The following is a description of a gene set: Genes up-regulated in CD8 T cells: naïve versus effectors. During acute viral infections, naïve CD8+ T cells differentiate into effector CD8+ T cells and, after viral control, into memory CD8+ T cells. Memory CD8+ T cells are highly functional, proliferate rapidly upon reinfection and persist long-term without antigen. In contrast, during chronic infections, CD8+ T cells become “exhausted” and have poor effector function, express multiple inhibitory receptors, possess low proliferative capacity, and cannot persist without antigen. To compare the development of functional memory T cells with poorly functional exhausted T cells, we generated longitudinal transcriptional profiles for each. studied in species Homo sapiens Human Gene Set: GSE41867_NAIVE_VS_EFFECTOR_CD8_TCELL_UP from publication Doering TA, Crawford A, Angelosanto JM, Paley MA, Ziegler CG, Wherry EJ (PMID 23159438), and this is the list of marker genes: MEN1, HTATIP2, LMAN2, NUBPL, SMARCB1, ANP32E, SSB, SEH1L, ATP11A, GNB1L, ELL2, ETV5, NEURL2 (NCBI Gene Id 140825), ARFGAP3, SNUPN, ROMO1, MAPRE2, PRSS16, ANAPC5, SIGMAR1, CDC16, PROS1, PCYT2, LIPT1, LGALS3BP, NGRN, EPRS1, ACTR3B, CST7, CENPM, TECPR2, CBX3, PSMD13, UQCC6, CAD, CCT5, PCCA, E2F1, SCN4A, PECR, GOLT1B, AKAP1, SAXO2, RALB, EDEM1, TECR, NABP1, MVD, HNRNPUL2, DCTN2, SGCB, RRP1B, TRMT12, E2F3, SPINK5, ATPAF2, DDX27, WDR76, SEC63, DLGAP5, FAM118B, DTL, PFAS, ANAPC11, C8orf76, NUCKS1, SPRED3, NOB1, GLO1, DDIT4, CDC123, MAP2K2, EHD4 (NCBI Gene Id 30844), NFIL3, CCNE2, MECR, PXMP4, RAB35, SAMHD1, GBP4, MCEE, DKC1, TTI2, CFAP210, PEX13, WDR77, CKAP2, CKAP2L, AKR1A1, FBXO2, PARP11, HDAC3, S100A13, DDX39A, NSDHL, POLR1D, PRR11, FBXO3, PPTC7, PLA2G12A, EED, BBS10, MPC2, PIGH, BTF3L4, PEX2, CCT8, MAP10, RAB8B (RAB8B, member RAS oncogene family), SNRPA1, MRPS10, SANBR, HSD17B7, CLUH, AACS, EIF2B3, DERA, SEC23A, ZNHIT6, G2E3, KCTD21, SLC44A1, ZNF708, C2orf49 (NCBI Gene Id 79074), SHCBP1, NPAT, TMEM126A, PON2, DZIP3 (NCBI Gene Id 9666), AP5B1, TMEM263, WASHC5, XDH, KGD4, CCDC88A, NSMCE1, LYAR, ANKRD39, UFSP1, PMPCA, WDR75, STT3A, WARS1, GNPAT, MRPS5, MRPS16, ARL5A, ELAC2, ALAS1, FANCD2, CTNNBIP1, AKIP1, TJP2, BHLHE40, ESF1, ORC1, OTUD6B, MVK, PUM3, TRAPPC6A (NCBI Gene Id 79090), SEC13, SPATA24, VIPAS39, IMMT, PHF13, RBM19 (NCBI Gene Id 9904), SNIP1, ZBTB42, HEMK1, PSME4, ACOT9, TSPYL4, LETM1, USP38, MRPS28, ST3GAL5, MTM1, HIVEP3, FBXL6, UQCRC2, PSMC1, MCM8, IFIT1, PRELID3B, PFKL, CCDC34, VMP1, RCL1, HMGCR, FAM229B, MTFR1, TMEM138, AIMP1, GPI (glucose-6-phosphate isomerase), ZC3HC1, GLRX3, GBP7, PGPEP1, THOC7, COX5A